The following is a description of a gene set: species: Homo sapiens Human Gene Set: GOBP_REGULATION_OF_OSTEOCLAST_PROLIFERATION Any process that modulates the rate, frequency, or extent of the multiplication or reproduction of osteoclasts, resulting in the expansion of an osteoclast cell population., and this is the list of marker genes: NMBR, OCSTAMP, PHF7, GREM1, PTH, NMB, TNFAIP3